Given this list of marker genes Kitl, Bcl2, Ap1g1, Bloc1s6, Rab38, Adamts9, Atp6ap2, Cd63, Ednrb, Bloc1s5 (biogenesis of lysosomal organelles complex-1, subunit 5, muted), Hps4, Oca2, Rab27a, Bcl2l11, Grk3, Dct, Sod2, Cited1, Ihh, Mlph, Edn3, Adamts20, Zic2, Gna11, Zeb2, Kit, Gli3, Lrmda, Mreg, Or51e2, Tpcn2 (NCBI Gene Id 233979), Bax, Ap3d1, Spns2, Vhl, Mef2c, Adamtsl4, Hps1, Enpp1, Vps33a, Ankrd27, Slc45a2, Hps5, Mitf, Myo5a, Rab32, Sox10, Ednra, Tyrp1, Pax3, Ap1m1, Bloc1s3, Gnaq, here is a description of the gene set: The developmental process that results in the deposition of coloring matter in an organism, tissue or cell. studied in species Mus musculus Mouse Gene Set: GOBP_DEVELOPMENTAL_PIGMENTATION